Given this list of marker genes DNAAF11, ODAD3, EIF2AK4, DLL3, ZIC3, DNAI1, GPC3, STK36 (NCBI Gene Id 27148), FOXF1, TMEM260, DAW1, DNAAF4, MMP21, ODAD4, RSPO2, B3GLCT, DHCR24, MCIDAS, GPC4, LFNG, NEK10, GDF1, BMPR2, FOXJ1, DNAAF3, RSPH3, RERE, CCDC40, NODAL, AFF4, SPAG1 (sperm associated antigen 1), DNAI2 (NCBI Gene Id 64446), DNAH9, ODAD2, DNAH1, RSPH4A, DNAH11, ACVR2B, RSPH9, SMC1A, DNAH5, RPGR, KDM6A, OFD1, LRRC56, NIPA1, MYRF, NME5, DRC1, NME8, HES7, HYDIN, DNAAF6, DNAAF2, MESP2, KMT2D, SFTPB, CRTAP, SPEF2, WT1, NIPA2, CFAP74, ZMYND10, CFAP298, RPS15A, CCDC39, CFAP300, GAS2L2, CCNO, RIPPLY2, DNAL1, TUBG1, CDC42, DNAAF1, DNAAF5, ODAD1, CITED2, CIROP, DNAJB13, CFAP221, RSPH1, CFAP53, TBX5, SMAD2, TTC12, MED12, here is a description of the gene set: studied in species Homo sapiens An abnormality of the pulmonary veins. Human Gene Set: HP_ABNORMALITY_OF_THE_PULMONARY_VEINS Abnormality of the pulmonary veins